The following is a description of a gene set: Human Gene Set: GAVIN_FOXP3_TARGETS_CLUSTER_P7 from publication Gavin MA, Rasmussen JP, Fontenot JD, Vasta V, Manganiello VC, Beavo JA, Rudensky AY (PMID 17220874) Regulatory CD4+ T cells (Tr cells), the development of which is critically dependent on X-linked transcription factor Foxp3 (forkhead box P3), prevent self-destructive immune responses. Despite its important role, molecular and functional features conferred by Foxp3 to Tr precursor cells remain unknown. It has been suggested that Foxp3 expression is required for both survival of Tr precursors as well as their inability to produce interleukin (IL)-2 and independently proliferate after T-cell-receptor engagement, raising the possibility that such 'anergy' and Tr suppressive capacity are intimately linked. Here we show, by dissociating Foxp3-dependent features from those induced by the signals preceding and promoting its expression in mice, that the latter signals include several functional and transcriptional hallmarks of Tr cells. Although its function is required for Tr cell suppressor activity, Foxp3 to a large extent amplifies and fixes pre-established molecular features of Tr cells, including anergy and dependence on paracrine IL-2. Furthermore, Foxp3 solidifies Tr cell lineage stability through modification of cell surface and signalling molecules, resulting in adaptation to the signals required to induce and maintain Tr cells. This adaptation includes Foxp3-dependent repression of cyclic nucleotide phosphodiesterase 3B, affecting genes responsible for Tr cell homeostasis. species: Mus musculus Cluster P7 of genes with similar expression profiles in peripheral T lymphocytes after FOXP3 loss of function (LOF)., and this is the list of marker genes: TLR7, SOCS2, NCOA7, GLIPR2, CYP2S1, BMPR2, SOSTDC1, SHE, GALM, TMEM158, MBNL3, C9orf152, MTMR3, SNN, GUCY1A1, GBP2, ARHGAP20, MSRA, RNF32, ANXA1, IFT80, AMIGO2, FGD6, APPL2, IFITM3, EVI2A, ENPP1, TTC39B, IKZF4, IGF2R, KCNK6 (potassium two pore domain channel subfamily K member 6), NT5E, PRNP, SELP, PDLIM4, APP, GATA1, PPIC, PRF1, XKRX (XK related X-linked), TRUB1, ITIH5, AGPAT4, TMEM64, CYFIP1, FOS, ST3GAL6, SPECC1, TNFRSF13B, QPCT, RESF1, HS3ST3B1, TMSB10, AFP, MAP6, RGCC, IL10, FASLG, LYST, MYO1E, DRC1, JUN (Jun proto-oncogene, AP-1 transcription factor subunit), GRAMD2B, NTRK3, EMP1, ACTN1, LRRC8D, MXD1, HECTD2, ENO3, AHCYL2, APOBR, GZMK, ENC1, DENND5A, KLRD1, DST (dystonin), LDLRAD4, WLS, ECM1, PRG4, HIPK2 (NCBI Gene Id 653052), PARD6G, ADAMTS6, DNAH12, USP27X, RABGAP1L, PPP1R3E, FAM89A, INAFM2, ABCB1 (NCBI Gene Id 5243)